Given this list of marker genes ATP2B4, ACTG1, HOPX, ANOS1 (NCBI Gene Id 3730), CRYAB, SLC1A1, RNASE1, RIN2, NEDD9, CDKN2B, LMTK2, LGALS3, SPARC, CLIC3, MATN3, S100A10, RIPK2, FADS3, EHD2, ELOVL5, STX11 (NCBI Gene Id 8676), KRT8, PDZD2, RNF128, FBLN5, HLA-C, CDKN1A, HCFC1R1, FOLR1, HACD1, PMP22, NCKAP5, ITLN2, SULT1A2, EPS8L2, SEMA6D, SUSD2, ARPC5, INF2, TNNC1, TM4SF1, TTC7A, RANBP17, CLDN18, ITPRIP (inositol 1,4,5-trisphosphate receptor interacting protein), GOLGA8A, RNF213, JADE1, WNT7A, HEG1, OSGIN1, SLC39A13, LMO7, KLF6, TMSB4X, NEXN, SMAD7, SLC2A3, ANO6, TMEM109, PTGS2, DENND3, N4BP1, CST6, CD55, PTPN21, CD47, TRIM16, MVB12B, DOCK11, ANXA3, UBC, RBP1, PLCE1, LAPTM4A, SDCBP, CD151, PDPN, PROS1, GPM6A, TMEM139, SFTA1P, VSIG2, SPINT1, COL12A1, KLK7, COL4A3, GGT1, ICAM1, DOCK4 (NCBI Gene Id 9732), TMOD3, PFKFB3, B3GNT7, FKBP9, MGAT3, FZD5, MT1X, ATP1B3, SLC39A8, PRR5L, RTKN2, PLEKHA1, GLS, ABI3BP (NCBI Gene Id 79859), LRRN4, STX3, PON2, CKB, DPYSL2, CYBRD1, DUSP7, ADRB2, ISG20, LAMC1, CFLAR, MS4A15, CELF2 (NCBI Gene Id 10659), GGTLC1, ARHGAP29, PTPN1, WASF3, TMPRSS2, NBEAL2, HPCAL1, GALNT18, CPM, LAMB3, AGER, ABCA7, ATP11A, POLR2L (RNA polymerase II, I and III subunit L), TGFBR2, MYRF, ZFP36, PEAK1, ENTREP1, LIMCH1, RGCC, EFNA1, NDNF, TSPAN15, COL8A1, C10orf67, CXCL16, IGFBP7, SPINT2, EPCAM, AGTPBP1, CCN1, C1orf198, TTLL7, SNX21, ACAA2, LAMC2, DIPK2A, TSPAN4, NDST1, TNFRSF12A, SLC6A4, NEDD4L, ABCA1, SULT2B1, ADRB1, OPN3, SPRING1, CLDN7, CUX1, VCL, MYO1B, MAP7D1, PLLP, CADM1, FAS, TPM4, EPB41L5, KRT19, HBEGF, EYA4, AGRN (NCBI Gene Id 389836), ANKRD29, RDX (radixin, NCBI Gene Id 5962), PRKCZ, PIEZO1, TACSTD2, KHDRBS2 (NCBI Gene Id 202559), SEMA5A, PAPSS2, TSC22D2, DAD1, FILIP1, B4GALT1, MYL9, CAV1, ABCA8, MYO1C, CCBE1, FLNA, ANXA2, SPTAN1, MSLN, SLC7A6, IRF1, PDLIM3, ARAP2, TIMP3, KIF5B, KCNN3, SGCE, OSGIN2, BCAP31, SLC40A1, MALAT1, DUSP1, SULT1A1, SBSPON, LIMS2, TUBA4A, HSPB1, PEBP4, FSTL3, COMT (catechol-O-methyltransferase), GJA1, ATF3, TSPAN13, MGLL, ANGPTL2, CNPPD1, VEGFA, GPRC5A, EHD1, P3H2, ECEL1P2, UNC13D (unc-13 homolog D), SPOCK2, ITGA3, COL4A2, CLDN4, SCD5, CNTN6, ZFYVE9, PPFIBP1, SH2D4A, PARP14, TES, NHSL1, TSPAN7, PARD6B, KRT7, HYAL1, GALK1, GADD45B, ACTB, ARHGEF26, NGF, EFEMP1, ATOH8, PPP1R15A (NCBI Gene Id 23645), LAMA3, FHL1, B2M, ST6GALNAC5, TMEM59, ST3GAL4, NEAT1, TNFAIP1 (TNF alpha induced protein 1), SCEL, SPTBN1, ERRFI1, PRSS8, FN1, PNPLA2, MYADM, EFR3B, KRT18, SNAP23, EMP2, PRDX1, MT2A, ARL6IP5, CEACAM6, TIMP2, PLEKHO1, CYP4B1, UPK3B, PLS3, CD9, EPB41L3, MYL6, SLC7A7, INSIG2, SEMA3E, TMEM179B, CLIC5, OTUD1, TXNDC11, DST, ITM2B, IL18, RHOF, FERMT2, CGN, EDN1, ACKR4, PGM1, GKN2, SDC1, B3GNT8, NTM, HIP1, PLAC8, ROR1, RAB11FIP1, RAB32, RRAS, GPRIN2, SERINC5, TPPP, NXN, SCNN1B, CLIP4, SEMA3B, STX12, TNS1, DLC1, PAX8-AS1, RASSF8, C14orf132, DAPK2, MT1E, GRK5, WFS1, TAGLN, PCYOX1, MYL12B, LPCAT3, SYNGR2, MAP2, SAMD4A, SNX22, CCN2, CAPN2, P4HA2, APLP2, COL4A4, PDLIM2, KLF2, H3-3B, TBC1D2, IL32, DNAJB1 (NCBI Gene Id 3337), HEBP1, YWHAH, CD63, CRIP2, ANKS1A, HSPB8, TACC1, SBDS, COL4A1, CYSTM1, GAS6, PTPRE, TOR1AIP2, B3GNT2, AHNAK, ALS2CL, BDNF, CLIC2, S100A4, SPRYD7, SRGAP2B, MYL12A, CAV2 (caveolin 2), CFL2 (NCBI Gene Id 1073), WWC2, PKDCC, PHLDB2, ZBED2, SFN, RAB31, ABLIM1, HSPG2, EVA1A, TUBB6, PDGFA, ALDH3A2, WNT3A, RASAL2, ANKRD1, AQP4, SSR2, here is a description of the gene set: from publication Travaglini KJ, Nabhan AN, Penland L, Sinha R, Gillich A, Sit RV, Chang S, Conley SD, Mori Y, Seita J, Berry GJ, Shrager JB, Metzger RJ, Kuo CS, Neff N, Weissman IL, Quake SR, Krasnow MA (PMID 33208946) studied in species Homo sapiens Human Gene Set: TRAVAGLINI_LUNG_ALVEOLAR_EPITHELIAL_TYPE_1_CELL